Given this list of marker genes ALMS1, CAV1, PPARG, FOS, CYP17A1, CAVIN1, GRIA1, AGPAT2 (1-acylglycerol-3-phosphate O-acyltransferase 2), TP63, BSCL2, here is a description of the gene set: Human Gene Set: HP_PRECOCIOUS_PUBERTY_IN_FEMALES Precocious puberty in females species: Homo sapiens The onset of puberty before the age of 8 years in girls.